The following is a description of a gene set: studied in species Homo sapiens Human Gene Set: WP_GENES_TARGETED_BY_MIRNAS_IN_ADIPOCYTES Genes targeted by miRNAs in adipocytes, and this is the list of marker genes: IGF1, MIR133A1, MIR1-1, HAND2, KCNJ2 (NCBI Gene Id 3759), HDAC4, ERG, MIR133B, TMSB4X, MIR133A2, HCN4, MIR1-2, HCN2, KCNQ1, PTBP2, KCNE1 (NCBI Gene Id 3753), SRF, GJA1